The following is a description of a gene set: studied in species Homo sapiens Abnormality of the amniotic fluid, which is the fluid contained in the amniotic sac surrounding the developing fetus. Abnormality of the amniotic fluid Human Gene Set: HP_ABNORMALITY_OF_THE_AMNIOTIC_FLUID, and this is the list of marker genes: PLAG1, LIFR (NCBI Gene Id 3977), LMNA, EBP, SLC25A26, BRCA1, TRAIP, FANCM, WDR35, FARSA, ZFX, FXR1, GRM7, MYCN, GDNF, ALDH7A1, ABCD1, SIN3A, VAC14, COG5, KDM6A, SHOC2, NRTN, ATP8B1, KMT2D, TPI1, UBE2A, ALB, ADNP, CHD8, GATA1, DOK7, ZIC3, SNORD116-1, MAGEL2, DYNC2I1, SLC26A3, TALDO1, NALCN, PIGO, AQP2, TWIST1, COL2A1, BIN1, LONP1, NEK8, SNAP25, FANCE, DYRK1A, EXT2, CHAT, ABCB4, GATA6, NRCAM, CDKN1C, IBA57, RAD51C, HSD17B4, PRDM13, CLCN7, TRPV6, TRIP11, SCN8A, CLTCL1, CSPP1, PNPO (pyridoxamine 5'-phosphate oxidase), FLVCR2, CREBBP, MDFIC, COMT, LAMB2 (laminin subunit beta 2), SPRED2, HBA1, HBA2, COASY, SOD1, TXNDC15, SKIC3, NPC2, RET, AMMECR1, XRCC2, DEF6, WNT9B, SEC24D, FUT8, FANCA, PIGQ, FANCG, GNB2, ECE1, WNT4, CILK1, AKT2, PGAP3, TPM2, CBL, TBCK, FILIP1, OTX2 (orthodenticle homeobox 2, NCBI Gene Id 5015), EDNRB, PHGDH, GBE1, RRAS2, EDN3, DPM2, ADGRG6, OTUD5, CSNK2A1, PIGY, ATP6V1B2, KCNJ1, SOX17, FKBP14, TMEM231, ALG9, DHPS, HSPA9, ATP7A, PLEC, HOXD13, LHX1, WDR81, MYH3, SLC5A7, SPINT2, SLC35D1, ALG12, MYL2, RPGRIP1L, GRIP1, EXTL3, AVPR2, MEG3, TRIP13, PSAT1, CA2, TFAM, EBF3, PIGV, POR, COL13A1, CFL2, MAP3K20, CHRNG, PALB2, FANCC, ERGIC1, MTO1, BRCA2, UQCC2, ERCC4, RAB34, ASXL3, FLNB, ALDH1A2, PWRN1, BUB1, NDUFB7, DHCR7 (7-dehydrocholesterol reductase), HYMAI, ADCY6, DYNC2LI1, NECTIN1, TMEM67, DPF2, SNRPB, VANGL2, OSGEP, LBR, GP1BB, KIF14, ATP6V0A1, BUB1B, SLC12A1, PRMT7, CPT2, CHRNA1, IPO8, MYPN (myopalladin), GPC3, ITGA8, ACTG2, TMEM237, SMG9, TRIP4, ZNF699, LMOD1, SEMA3E, TBX1, SV2A, HIRA, H19, B3GALT6, UROD, ERBB3, MUSK, PKHD1, CDC42BPB, MAP2K2, RNF2, RSPO2, LMOD3, FANCF, HACD1 (3-hydroxyacyl-CoA dehydratase 1), ACTB, ARVCF, ZC4H2, EGFR, ALG14, CNTN1, KIAA0586, BNC2, HMGA2, VAMP1, SLC35A2, RIT1, MYO9A, KIF21A, AGTR1, SLC25A12, GPC4, DALRD3, ADARB1, ABCC6, CRB2 (NCBI Gene Id 286204), TBX4, DMPK, B9D1 (B9 domain containing 1, NCBI Gene Id 27077), TBC1D24, ASCC1, TMEM216, CHD7, TSEN54, PDX1, BICD2, DDX6, FANCL, MADD, RREB1, TMEM70, FIG4, BRAF, WDR73, COX14, TMEM107, DONSON, RAF1, NEB, CEP57, UBAP2L, KLHL40, CLCNKB, DIS3L2, HADHA, RMND1, IARS1, WNT3, TCTN1, SNORD115-1 (small nucleolar RNA, C/D box 115-1), SZT2, CD96, UROS, GLDN, SLX4, SREBF1, MAMLD1, MYL9, LARS2, BUB3 (NCBI Gene Id 9184), CNTNAP1, OFD1, ITGB4, MOGS, CHRM3, IFIH1, MYF6, PCGF2, SYT2, RPL11, UBE2T, FANCI, ESCO2, SLC18A3, B3GLCT, PLAGL1 (NCBI Gene Id 5325), RHCE, SNRPN, SATB1, ALG1, MAD2L2, ATP6V1E1, MYL1, VPS33B, RAD51, PLVAP, ATAD3A, NRAS, MSX1, NR1H4, SEMA3D, ATN1, RERE, JMJD1C, FBLN5, PHIP, MAFB, ASCL1, SYNE1, DNM2, RTL1, HYLS1, PBX1, KIDINS220, TSEN2, MAGED2, CERT1, SELENON, ALPL, CLCNKA, PLPBP, MKRN3, TP63, FANCD2, ZMPSTE24, GLE1, KRAS, FGF20, AGRN, LTBP3, AGT, COL11A2, NAA10, PTH1R, SLC25A1 (NCBI Gene Id 6576), STRADA, PHACTR1, PPP1CB, SMO, SCN4A, EP300, DZIP1L, ALX4, ITGA7, MYLK, GLI3, TMCO1, SLC2A1, ERF, NUP88, SOS1, EFEMP2, KLHL41, ODC1, HIC1, TCTN2, FOXF1, FH, SLC25A46, TNNC2, SLC27A4, JUP, SOX9, ROBO1, FGFR2, CDK13, TUBA1A, WBP4, FOXE1, IRF6, TTC7A, CLPB, IKZF1, KCNJ6 (potassium inwardly rectifying channel subfamily J member 6), DSP, PAFAH1B1, FGFR3, CALCRL, PRRX1, KIF7, RPGRIP1, FBN1, CEP290, PAX2, SLC16A2, SETD1A, ENPP1, MKS1, INPPL1, TRAPPC12, MTHFR, ITGA6, ERBB2, KDM3B, DLK1, RAPSN, GMPPB, SCYL2 (NCBI Gene Id 55681), PIGN, FANCB, CEP55, MTMR14, MTM1, TCTN3, PIGA (phosphatidylinositol glycan anchor biosynthesis class A), C1QBP, MYOD1, EXOSC9, PUF60, FARSB (NCBI Gene Id 112957), SEC24C, CC2D2A, RFWD3, PI4KA, RPL10, MBTPS2, DTYMK (NCBI Gene Id 9102), ASXL1, SLC25A24, INSR, TBCD, PIEZO1, SPOP, YWHAE, SLC6A5, PIGL (NCBI Gene Id 9487), FRA10AC1, KAT6B, CHRND, GFRA1, GNPTAB (NCBI Gene Id 79158), NDUFA6, IFT56 (NCBI Gene Id 79989), ADAMTS3, HS2ST1, SEMA3C, UFD1, ZBTB42, KBTBD13, IGF2, TPM3, LZTR1, PMM2, GBA1, PPP1R13L, MYH11, ALG8, BRIP1, HNF1B, REN, NPAP1, CCDC47, NPHP3, INVS, TOR1A, SEC61A1, ADAT3, HRAS, PIGW, RHAG, RHD, TAPT1, BSND, ABCB11, NEK9, DOCK6, PWAR1, COL25A1, SLC9A3, SFXN4, DPH5, PGAP2, B9D2, GREB1L, RBM10, SLC26A2, PHOX2B (paired like homeobox 2B), CRELD1, HERC2, HSPG2, PAICS, RNU4ATAC, BMPER, ATP1A2, RYR1, PLAA, ACE, ANO1, COQ7, DYNC2I2, ACTA1, FREM2, AMER1